Given this list of marker genes H2bc3, H2ac12 (H2A clustered histone 12), H2ac8, H4c9, H4c1, H4c8, H3c3, H2bc6, Zfp960, Zfp317, H2ac6, H2az2, Zfp677, BC024063, H4c18, Zfp454, Gm3604, H4c16, Zfp934, H2bc23, H2bc8, H2bc7, H2bc13, B020011L13Rik, Gm14399, 4930522L14Rik (NCBI Gene Id 78020), Zfp97, H3f3a, H3c8, H2bc1, Zfp1004, H2bc26, Trim28, Zfp54, H3c7, Zfp932, Atf7ip, H4c17, H3c2, Zfp354a, H4c4, H2aj, H2ac11, H2ac15, Gm4767, H3c13, H2ab1, H4c3, H3c10, H2ab2, H3c15, H2bc11, H3f3b, Zfp345, H2bc9, H2bc14, H2ac4, H3c6, H4c14, H2ac20, Zfp950, H4c11, H3c4 (NCBI Gene Id 319149), Zfp442, Zfp324, Gm10778, H2ax, Zfp708, H3c11 (NCBI Gene Id 319153), H2bc21, Zfp976, Zfp937, H2ac13, Zfp975, H2bc12, H3c14, Zfp382, H2ac7, H4c12, Zfp433, H2bc22, Gm5141, H3c1, Setdb1, H2ac22, H2ac24, H2bc4, Zfp872, Zfp873, Zfp160, H2ac18, Zfp53, H2ab3, H2bc15, H4c2, H2ac10, Gm6871, Zfp970, H4c6, Gm15446, H2ac19, H2ac23, H2bc24, Zfp1007, Zfp997, here is a description of the gene set: Regulation of endogenous retroelements species: Mus musculus Mouse Gene Set: REACTOME_REGULATION_OF_ENDOGENOUS_RETROELEMENTS